The following is a description of a gene set: CD4+ T cells that selectively produce interleukin (IL)-17, are critical for host defense and autoimmunity1-4. Crucial for T helper17 (Th17) cells in vivo5,6, IL-23 has been thought to be incapable of driving initial differentiation. Rather, IL-6 and transforming growth factor (TGF)-β1 have been argued to be the factors responsible for initiating specification7-10. Herein, we show that Th17 differentiation occurs in the absence of TGF-β signaling. Neither IL-6 nor IL-23 alone efficiently generated Th17 cells; however, these cytokines in combination with IL-1β effectively induced IL-17 production in naïve precursors, independently of TGF-β. Epigenetic modification of the Il17a/Il17f and Rorc promoters proceeded without TGF-β1, allowing the generation of cells that co-expressed Rorγt and T-bet. T-bet+Rorγt+ Th17 cells are generated in vivo during experimental allergic encephalomyelitis (EAE), and adoptively transferred Th17 cells generated with IL-23 in the absence of TGF-β1 were more pathogenic in this experimental disease. These data suggest a new model for Th17 differentiation. Consistent with genetic data linking the IL23R with autoimmunity, our findings re-emphasize the role of IL-23 and therefore have important implications for the development of new therapies. Human Gene Set: GSE23505_IL6_IL1_IL23_VS_IL6_IL1_TGFB_TREATED_CD4_TCELL_UP studied in species Homo sapiens from publication Ghoreschi K, Laurence A, Yang XP, Tato CM, McGeachy MJ, Konkel JE, Ramos HL, Wei L, Davidson TS, Bouladoux N, Grainger JR, Chen Q, Kanno Y, Watford WT, Sun HW, Eberl G, Shevach EM, Belkaid Y, Cua DJ, Chen W, O'Shea JJ (PMID 20962846) Genes up-regulated in CD4 T cells: IL1B, IL6 and IL-23 versus IL1B, IL6 and TGFB1., and this is the list of marker genes: CKAP2, CD14, ERCC6L2, EDN1, VCAN, POU2F1, ARMC5, AQP1, SLC40A1, RNASEL, ATF3, GANC, GDPD5, BLVRB, CD47 (CD47 molecule), ALOX5AP, BUB3, RHAG, IL7, MGP, GDF10, FCGR2A, RPL10, SLC47A1, CCR5, GPSM3, MTCH1, ZBTB33, ACY1, CASP12, ANXA6, OMA1, NDUFA9, MOB1A, SMCO4, GABRP, TNFSF13B, SOCS3, P2RY4, GLRX, HPF1 (histone PARylation factor 1), NDUFB7, SNX18, MAPK13, PSPC1, ZYX, MRPL39, SLAMF9, CCT7, APLNR, RABL6, AUTS2, SAMM50, MX2, RAD23A, DDRGK1, FCER2, CLEC6A, ADAP2, SPOCK3, PBX3, PCDHB10, ABCC9, GALK1, RGS5, SRD5A3, FMNL1, ETHE1 (NCBI Gene Id 94930), OGFR, IFT70A, ACTRT1, SFT2D1, ATP8A1, PSMB1, MTRES1, SNTB2, BZW2, POU2F2, LHPP, TMEM209, MED28, CAMK2G, MYBBP1A, OTUB2, ANKMY2, DDAH2, ID3, LUM, NDUFA7, DUSP12, FANCA, MAIP1, CXCL12, TRIM24, MMP3, RPGRIP1, TAF12, ZFYVE19, ZNF394, DCTPP1 (dCTP pyrophosphatase 1), PHAX, IFIT2, CD5, ITIH4, FERMT3, NOTCH3 (NCBI Gene Id 791), AHSG, MYD88, SPRYD4, DNAAF4, ARL2, TIFA, CXCR5, BCL2, FAM53C, B3GNT9, SUV39H2, RNASEK, AKR1D1, MRPS17, CALML4, MMP2, TSPAN9, ARFGAP3, TSLP, DIAPH3, GAA, ARMCX4, EXOSC2, SFRP4, ATP13A1, LTA, CCNC, SOCS1, WDFY3, ZBP1, DOK3, HOXA11-AS, TREX2, IFIT3, CYGB, RCOR1, CLEC1B, BLTP2, PDCD6IP, H2AJ, DCN, NGDN, ZBTB44, SLC16A6, TESC, MAN1B1, MELTF, ITIH3, SNRNP40, SYNPR, DHX58, IL33, TSEN15, NELFB, HMOX1, WWP2, TCOF1, OAS2, CLEC14A, EHD4, PILRA, VTN, MYG1, CCDC107, ING1, BCL11A, ERCC6L, UBXN2B, PSMB10, EIF3K (NCBI Gene Id 55373), ATXN7, CYB5R1, CSK, E2F5, TMEM234, TMEM161A, TMEM140, GNPNAT1, LYL1, CLEC4F, SLFN13, RIPK3, BIK, ERP29, CSF3R, RASGRF2, SLCO2A1, MRPL9, ATP13A2, NOA1, KLHDC8A, COL5A2, LCMT1, ERI3